Given this list of marker genes CELA2A, HAVCR2, LEP, GPIHBP1, LPL, AGPAT2, AGL, EMD, CREB3L3, PCSK9, PIK3CG, ABCG5, ARMC5, LMAN1, SYNE1, CPT2, PYGL, IFT74, BBS7, STX11, TBCK, DEAF1, LMF1, CFHR3, CIDEC, NPHS1, GYS2 (glycogen synthase 2), SNORD115-1, ACTN4, ASL, APOE, MCFD2, CNBP, XIAP, SAR1B, ABCG8, SLC29A3, RAI1, TTC8, FECH, SLC7A7, GNAS, WRN, LIPE, PSMB8, WDPCP, EXTL3, DEF6, GLA (NCBI Gene Id 2717), ABCA1, PIGT, MC4R, FHL1, AIP (aryl hydrocarbon receptor interacting protein), LIPC, CPT1A, ADCY3, SGPL1, APOA5, DGAT1, LEPR, RSPO1, LYST, PLVAP, MTX2, STXBP2, CFHR1, LDLR, ALB, MYT1L, G6PC1, FOS, SCLT1, PSMB10, LIPA, IFT27, DYRK1B, POLD1, AKT2, LCAT (NCBI Gene Id 3931), GPR101, GK, SYNE2, IFT172, FARSA, TTPA (NCBI Gene Id 7274), LZTFL1, ABHD5, ARL6, PWRN1, ZMPSTE24, BSCL2, SDCCAG8, NPHS2, PLAAT3, MYO5A, BBS9, BBS10, SLC25A13, ADRA2A, RAB27A (RAB27A, member RAS oncogene family), BBS12, MCM10, PHKG2, LRP6, XRCC4, FLII, PHKB, TRIM32, GPD1, NPHP1, BBS5, NSMCE2, DCAF17, HERC2, CYP7A1, CFAP418, PRF1, CYP19A1, PPARG, SNORD116-1, AEBP1, MKRN3, BBS4, POLR3A, CAVIN1, APOB, PNPLA2, SH2B1, PCYT1A, BBIP1, ALMS1, YARS1, MAGEL2, PWAR1, BBS1, SLC19A1, CEP19 (centrosomal protein 19), APOC2, IQSEC2, SMARCAL1, PIGH, MKS1, PHKA2, NPAP1 (nuclear pore associated protein 1), PSMB4, LMNA, JAG1, SMPD1, MKKS, SCAPER, SLC2A2, TNFRSF9 (NCBI Gene Id 3604), UNC13D, KDM1A, CAV1 (NCBI Gene Id 857), BBS2, TFG, CFH, PLIN1, TMEM43, SLC37A4, LDLRAP1, CEP290, here is a description of the gene set: An elevated lipid concentration in the blood. Hyperlipidemia Human Gene Set: HP_HYPERLIPIDEMIA species: Homo sapiens